The following is a description of a gene set: species: Homo sapiens from publication Ferrando AA, Neuberg DS, Staunton J, Loh ML, Huard C, Raimondi SC, Behm FG, Pui CH, Downing JR, Gilliland DG, Lander ES, Golub TR, Look AT (PMID 12086890) Human T cell leukemias can arise from oncogenes activated by specific chromosomal translocations involving the T cell receptor genes. Here we show that five different T cell oncogenes (HOX11, TAL1, LYL1, LMO1, and LMO2) are often aberrantly expressed in the absence of chromosomal abnormalities. Using oligonucleotide microarrays, we identified several gene expression signatures that were indicative of leukemic arrest at specific stages of normal thymocyte development: LYL1+ signature (pro-T), HOX11+ (early cortical thymocyte), and TAL1+ (late cortical thymocyte). Hierarchical clustering analysis of gene expression signatures grouped samples according to their shared oncogenic pathways and identified HOX11L2 activation as a novel event in T cell leukemogenesis. These findings have clinical importance, since HOX11 activation is significantly associated with a favorable prognosis, while expression of TAL1, LYL1, or, surprisingly, HOX11L2 confers a much worse response to treatment. Our results illustrate the power of gene expression profiles to elucidate transformation pathways relevant to human leukemia. Nearest neighbors of LYL1, based on the close agreement of their expression profiles with that of LYL1 in pediatric T cell acute lymphoblastic leukemia (T-ALL). Human Gene Set: FERRANDO_LYL1_NEIGHBORS, and this is the list of marker genes: SELL, RHOA, TNFRSF1A, LGALS9, HHEX, BCL2, APEX1, LMO2, ZBTB16, LSP1, TRDC, CCND2, IL9R, FES, SOD2, MYCN, CD34